Given this list of marker genes NPY, SLC18A1, SNCA, UNC13C, GRIK3, RAB5A, SYNJ1, RAB3A, UNC13A, CABP4, AP1S1, CALB2, PRKN, CALB1, NMU, AP3D1, CPLX2, NTRK2, SYP, GRIK2, PRNP, UNC13B, USH2A, CAD, SCGN, OPHN1, TBC1D24, CPLX4, PRSS12, AAK1, SLC4A8, TNN, KCNC2, CNGB1, NTSR1, GRIN1, LRRK2, SLC18A3, CPLX1, OXT, CPLX3, SLC18A2, ADORA1, MICAL1, GHRH, here is a description of the gene set: species: Homo sapiens Terminal inflated portion of the axon, containing the specialized apparatus necessary to release neurotransmitters. The axon terminus is considered to be the whole region of thickening and the terminal bouton is a specialized region of it. Human Gene Set: GOCC_TERMINAL_BOUTON